The following is a description of a gene set: from publication Cui A, Huang T, Li S, Ma A, Pérez JL, Sander C, Keskin DB, Wu CJ, Fraenkel E, Hacohen N (PMID 38057668) species: Mus musculus Mouse Gene Set: CUI_MACROPHAGE_M_CSF_RESPONSE_UP Genes positively differentially expressed in cell type: Macrophage upon treatment with cytokine: M-CSF in mouse lymph nodes in vivo. Cytokines mediate cell-cell communication in the immune system and represent important therapeutic targets. A myriad of studies have highlighted their central role in immune function, yet we lack a global view of the cellular responses of each immune cell type to each cytokine. To address this gap, the authors created the Immune Dictionary, a compendium of single-cell transcriptomic profiles of more than 17 immune cell types in response to each of 86 cytokines (>1,400 cytokine-cell type combinations) in mouse lymph nodes in vivo. A cytokine-centric view of the dictionary revealed that most cytokines induce highly cell-type-specific responses. For example, the inflammatory cytokine interleukin-1β induces distinct gene programmes in almost every cell type. A cell-type-centric view of the dictionary identified more than 66 cytokine-driven cellular polarization states across immune cell types, including previously uncharacterized states such as an interleukin-18-induced polyfunctional natural killer cell state., and this is the list of marker genes: Gtpbp4 (GTP binding protein 4), Imp4, Tubb6, Bola2 (NCBI Gene Id 66162), Clic4, Lgals3, Bcl2a1b, Gch1, Nr1h3, Eef1e1, Anp32b, Atp6v1b2, Actr3, Lpl, Akirin1, Plek, Cycs, Ncl, Tuba1c, Ran, BC005537, Sqstm1, Ccl2, Pfn1, Ccl6, Actg1, Ccl7, Cstb, Ccl9, Sdc4, Srm, Ccl12, Dok2, Ranbp1, Cxcl16, Nap1l1, Eif4a1 (NCBI Gene Id 13681), Cxcl10